Given this list of marker genes H2ac1, H2ac10, H2bc15, H2ac7, H4c9, H2bc1, H2bc12, H4c14, H4c8, H2ac12, Mpg, H4c1, H2bc27, H2ax, H2bc8, H2ac15, H2ac20, H2ac8, Terf1, H2bc9, Acd (adrenocortical dysplasia), H4c3 (NCBI Gene Id 319155), H2ac13, H2ac19 (NCBI Gene Id 319192), H2bc11, H2ac6, H4c2 (H4 clustered histone 2), H2ac24 (H2A clustered histone 24), H4c12, H2bc22, Ogg1, H2bc13, H2ac22, H2ac23, H4c17, H2ac4, H2bc7, H4c6, H4c18, H2ac11, Terf2, H4c4, H2bc3 (NCBI Gene Id 319178), H4c11, H2az2, Mutyh, here is a description of the gene set: electronically inferred by orthology from the curated human pathway This event has been computationally inferred from an event that has been demonstrated in another species.<p>The inference is based on the homology mapping from PANTHER. Briefly, reactions for which all involved PhysicalEntities (in input, output and catalyst) have a mapped orthologue/paralogue (for complexes at least 75% of components must have a mapping) are inferred to the other species. species: Mus musculus Reactome Pathway: Cleavage of the damaged purine part of: Depurination